Given this list of marker genes Cpsf4, Pip5k1a, Cstf2, Csnk1a1, Cpsf7, Marveld3, Ssu72, Nudt21, Cpsf4l, Fip1l1, Wdr33, Cstf2t, Cpsf3, Sympk, Zc3h3, Tut1, Cpsf2, Cpsf1, Cpsf6 (cleavage and polyadenylation specific factor 6), here is a description of the gene set: Mouse Gene Set: GOCC_MRNA_CLEAVAGE_AND_POLYADENYLATION_SPECIFICITY_FACTOR_COMPLEX A multisubunit complex that binds to the canonical AAUAAA hexamer and to U-rich upstream sequence elements on the pre-mRNA, thereby stimulating the otherwise weakly active and nonspecific polymerase to elongate efficiently RNAs containing a poly(A) signal. studied in species Mus musculus